Given this list of marker genes Gm22455, Kcnh8, Cripto, Irak3, H2az1, 1110025M09Rik, Lasp1, Zfhx2, Srsf7, Rpl36al, Gm29417, AA386476, Upp1, Epc1, Trim8, Tlnrd1, Polr2a, Gm12536, Rrm2, H2ac15, Rpl27, Gm12100, Gm24451, H2ac21, Mttp, Mllt6, Raly, Rpl3-ps1, Atxn7l3, Cdh1, Rigi, Ccne2, Nynrin, Ndufaf3, Pim3, Snhg9, Mgme1, Hmgcr, Gm12279, Sphk2, Rpl31, Mta2, Cbx3, Mcm7, Snora74a, Kansl1, Pipox, Ing2, Zc3h12a, Tcte2, Tpi1, Hsd17b14, Zic5, Trappc4, Agpat4, Hcfc1, Snora41, Nr0b1, Lrsam1 (leucine rich repeat and sterile alpha motif containing 1), B3galt4 (UDP-Gal:betaGlcNAc beta 1,3-galactosyltransferase, polypeptide 4), Skp1, Gpx4, Mir7079, Nr5a2, Ccnd1, H2ac4, Sumo2, Tnfsf13os, Pfn1, Rrp36, B3gnt2, Myl12b, Snhg20, Snord118, Gm26457, Mir7650, Ddx3x, Cbx7, H3c15, Atp6v1a, Bcl7a (NCBI Gene Id 77045), Gm22579, Hmgn2, Rps10, Rpl22l1, BC005537, Nrf1, Slc7a3, Snord14a, Midn, BC051226, Senp3, Snord45b, H4c18, 4930461G14Rik, Arl15, Mad1l1, Sgo1, Grik3, 6330403L08Rik, Zbtb37, Egr1, Nfyb, Rpl7a, Gm15459, Rpl5, Snord65, H3c14, Hotairm1, Tead1, Ddx6, Zfp36l2, Rpl6, Gm22980, 4933440N22Rik, E230029C05Rik (NCBI Gene Id 671286), Lamtor2, Eif2s2, Phc1, Gm25296, Tfe3, Gm12101, Gm22571, Cox20, Igfbp2, Zwilch, H3c3, Gm26205, Snora17, Rbpms2, Gpbp1, Cbx5, Rpsa, Mir292, Snora24, Hmox1, Chtop, Senp6, Slc7a7, 4833445I07Rik, Jade1, Catsper2, Mir20b, Rps2, Sall1, Mir18b, Rrs1, H4c8, Gse1, Gm13830, Mir6352, Bola1, Itga6, Fbxo38 (F-box protein 38), Tjp2, Trmt10a, Atxn2l, Cdc73, Snord49b, Mir19b-2, Plekha4, Mycn, Gm10138, Moap1, Npm1, Otop1, Etl4, Rpl36a, Tgif1, 1700039I01Rik, Surf1, Ncl, Rbpms, Slmap, Slc25a39, H2ac12, Naa12, Zfp57, Btg2, Gt(ROSA)26Sor, Hdgf, Sox11, Trh, Utp14b, Rab26os, Lefty1, Rpl14, Ep300, Zfp42, Gm15860, Mir290a, Prickle1, Mat2a, Gm25744, Hnrnpa0, 2900009J06Rik, Snora33, Trp53cor1, Ino80dos, Wapl, Rpl12, Aqp3, Herpud1, Mir8120, Jmjd6, Sox2ot, Mir106a, Bahcc1, Mtf2, Lemd2, Wrap53, Pnrc2, Gemin7, Klf2, Kntc1, Bcl3, Scd2, Rpl10a, Tbl1xr1, Gatad2a, Smg5, H3c4, Gm26728, Septin9, 6530411M01Rik, Nop2, Traf7, H1f1, Dpagt1, Nme2, Mir3091, Rpl10, Sall4, 2700078F05Rik, Dnmt3bos, Mgat4b, Mettl23, Gm20652, Rbmxl1, Snhg6, Tfap2c, Mir92-2, Spred1, Xpo1, Arhgef2, Rtraf-ps, Fgf4, H2bc18, H2ac13, Rpl28, Epb41l4aos, Pou5f1 (POU domain, class 5, transcription factor 1), Snora69, Snord104, Cyfip1, Amd1, Glul, Sumo1, Fam169b, Spen, Slc2a3, Hspa8, Eno1, Tefm, Lpar6, Tmem131, Hmga1, Gm24044, Zfp710, Wbp1, Cltc, H4c1 (NCBI Gene Id 326619), Ubb, Dpy30, Gldc, Rcc1, Septin1, H2ac14-ps, Anp32e, Dusp6, D930048N14Rik, Ubqln4, Gm32950, Il17d, Zbtb25, Cggbp1, Gm23187, H2af-ps2, Gm12974, Lrrc8d, Pml, Arid1a, Snhg3, H2bc3, Etv4, Tdh (NCBI Gene Id 58865), 1700016A09Rik, Rps12 (ribosomal protein S12), Gm23201, Mir290b, 2410006H16Rik, Set, Gm24455, Ttc39d, Nop56, Rpl13, Fblim1, Gm22357, Gm12980, Lmln, Rps23, Tcf15, Slc29a1, Znfx1, A230083N12Rik, Zfp219, Snhg8, Ube2k, Fut9, Ahdc1, Zfhx3, Dedd, Fem1b, Mcl1, Usp37, Sox12, Snord68, Trip12, Wsb2, Ubc, Dusp1, Yars2, Srsf2, Chd2, Enah, Ywhaq, Snord59a, Snord1a, Snora62, Zmynd8, H2ac8, Hnrnpc, Actg1 (actin, gamma, cytoplasmic 1), Rundc3a, Snhg12, H4c4, Patz1, Gm22489, C330002G04Rik, Snora26, Zfp704, Rplp0, H4c2, Eef2, Eif5a, Mir6935, Stx3 (syntaxin 3), Rnd3, Snord15a, Mt1, H2ac5-ps, Pten (NCBI Gene Id 70161), Zfp706, Gdf3, Msantd3, Acot13, Setd5, Gm26608, Chaserr, Gm26885, H2ac19, Slc25a36, Cnot8, Snora52, Ipo7, Ndufa13, Dnajb4, Gpa33, Setd1b, Sema6a, Tuba1a, Esrrb, 5730420D15Rik, M6pr, Rps8, Srsf1 (NCBI Gene Id 70724), Mllt10, Nphs1os, Pcgf2, Dapk3, Mir124a-1hg, Atp5f1b, Snord52, Gm10382, Smad7, Rarg (NCBI Gene Id 19411), Birc2, Hspe1, H2bc22, Snora61, Surf2, Snord12, Zbtb8os, Tpt1, Gm25894 (predicted gene, 25894), 1600020E01Rik, Prdx1, Rfc4, Gm23301, Scd1, Med22, Ddit4, Dnaja1, 6330562C20Rik, H4c6 (H4 clustered histone 6), 2610035F20Rik, Sqstm1, Gm25835, 9330151L19Rik (RIKEN cDNA 9330151L19 gene), H1f3, Slc9a2, N4bp3, Zfas1, H3c2 (H3 clustered histone 2), Snora68, E230016M11Rik, Rpl37, Rbmxl2, Sde2, Rps18, Calm1, Actb, Mir1949, Bend3, Gm4419, E2f3, Bcat2, Hnrnpa2b1, H1f4, Gm24016 (NCBI Gene Id 115490074), 0610009L18Rik, Gm12925, Smim14, Pabpc1, Apoe, Epop, Ubtf, Altre, Trp53bp1, Snord83b, Ss18, Tmem253, Gabbr1, Vangl1, Gm31266, Gm26766 (NCBI Gene Id 108168238), Mir291b, Ark2c, Kmt5a, Mat2b (NCBI Gene Id 68881), Rpl9, Etf1, Sgk1, Snord1b, Alg13, Gm26224, Pdk1, H2bc8, Sulf2, Gm9887, Snord82, Ints5, Notum, Gm23130, Mup6, Snora78, Rplp2, Asns, Rps17, Rps15, Snapc5, Hk2, Cd9, H4c9, Gm24086 (NCBI Gene Id 115487627, predicted gene, 24086), H3c11, Tanc1, Snrpn, Id3, Gm26448, H3f3b, Myl6b, H3c6, AI480526, Cdc42se1, Plekhf2, Mir7067, Rcc2, 1700008O03Rik, Cnpy1, Rps5, Acsl3, Ints6, Mir6516, 1700019D03Rik, 4933417C20Rik, Vdac1, Snord110, C130036L24Rik, Gtf3c6, Snord58b, BC031181 (cDNA sequence BC031181), H2bc27, Sema4b, Hnrnpa1, Hmgb2, Serpina3i, Gm22984, Gm25867, Neat1, Hspa5, Ndufa7, Ndufb10, Dst, Snord13, Psmd11, Mir291a, Hsp90aa1, Snora16a, Sfpq, Hnrnpdl, Gapdh, Rpl22, Jmjd1c, Resf1, Slc38a1, Abcg1, Dbf4, Utf1, Snord73b, Tfrc, Mir1894, Rps9, Tet1, Frmd8os, 2810004N23Rik, Nhsl3, Dgkh, Mir292b, Srm (spermidine synthase), Gm11772, Tmpo (thymopoietin), Ccn2, 1700023H06Rik, Nop58, Clhc1, Tsc22d1, H2ac22 (H2A clustered histone 22, NCBI Gene Id 319170), Pdf, 1700096K18Rik, Rps28, Snord4a, Tmem39a, En2, Vps52, H2ax, Rpl18, Mir207, Fam169a, Slc3a2, Zic2, Snord99, Snord60, Zscan10, Tenm4, Insig1, Zc3h10, Epha2, H2bc12, Klf3, Gas5, Rps27a, Gm22711, Gm25855, Mir293, Zbtb8a, Rab34, Pank1, Schip1, Rpl35a, Lyset, Gm11398, Gm23969, Cic, Apol7d, Gm43403, Arrdc3, Nufip2, Mir363, Azin1 (NCBI Gene Id 73525), Rpl18a, Gm25878, Mideas, Mir5136, Suz12, Cd68, Iqcg, Slc2a1, Fxr1, Slc25a12, Tardbp, Msh2, Snora57, D130058E05Rik, Snx5, Mrps18b, Snord45c, Sulf1, Eif4a1, Lbr, 3010003L21Rik, Lmnb1, H2ac20, Malat1, Rbbp4, Gm15441, Rpl23a, Pgk1, Tubb5, Snora73a, Tmem79 (transmembrane protein 79), Mirlet7i, H3c7, Tet2, Rpl13a, Hnrnpf, Eapp, Gm14024, Tbx3, Gid8, Snora64 (NCBI Gene Id 104366), Hsp90ab1, Rpl21, Fzd5, Snora21, 2610037D02Rik, Rnu7 (NCBI Gene Id 19866, U7 small nuclear RNA), Mesd, Hnrnpab, Slbp, Rplp1, Ndufs1, Gm16096, Tbc1d10b, Hoxa1, Acp6, Etnk1, Gm11335, C230096K16Rik, G3bp2, Zfp568, H2bc11, Ptbp1, Rps20, Amotl2, Elovl6, H2bc13, Ntn1, Rest, Mllt11, Snord87, Tbc1d8, Gpi1, Sox2, Birc6 (baculoviral IAP repeat-containing 6), Slc20a1, Tiparp, Mir1907, Dsg2, Pdgfa, Gm15420, Usp31, 5730405O15Rik, Hnrnpa3, B4galt6, Btg1, Dppa5a, Hnrnpll, 1810059C17Rik, H2bc6, Dnmt3b, Trim28, Ptp4a2 (protein tyrosine phosphatase 4a2), Fscn1, Aldoa, Jarid2 (jumonji and AT-rich interaction domain containing 2), Gm20033, Snord43, Trib3, Rpl11, Snora3, Mfsd11, Gm26511, Rabggtb, Mybl2, Cdk9, Rpl39, Rbm47 (NCBI Gene Id 338502), 5430416N02Rik, Gm15222, Mkrn1, Gm23202, Ccnl1, Ubald2, Daxx, Myl12a, Snora73b, Cradd, a, Cdk5rap2, Gm24452, Gm24029, Pdia3, Lncenc1, Txnip, Socs2, Ap4m1, Srsf5, Anp32b, Hells, Ddx39a, Mindy1, Hnrnpu, Tm7sf2, Dnajb14, H4c3, Pou4f2, Ddx5, Mobp, Gm23639 (predicted gene, 23639), Ftl1, Ubl3, Eed, Gm26202, Ppp1r15a, Commd5, Mir17hg, H2ac7, Gm19705, Snord42a, Mylpf, Spmap1, Mir191, Mtcl1, Spink10, Crebzf, H2bc15, Gm19721, Phf23, Gm23344, Gm23455, Znhit2, Eef1g, Tle4, Zfp36l1, Gm4285, Snord2, Zbtb7a, H2bc7, Gm25091, H4c11, Snora44, Lypla1, Gcn1, Prune1, Pbld2, Kis2, Rpl41, Rnu11, Eef1b2, Ino80d, Zfp428, Snhg7os (small nucleolar RNA host gene 7, opposite strand), Snhg5, H4c14 (NCBI Gene Id 97122), Rps26, L1td1, Snord49a, H3c13, Mir1893, H3c1 (H3 clustered histone 1), Tti2, Eif4g2, Grcc10, Shld2, Bcat1, Ctbp2, Eif1, Eif4e2, Rps11, Snord42b, 2810013P06Rik (RIKEN cDNA 2810013P06 gene), Gm10244, Hs6st1 (NCBI Gene Id 50785), Rnf157, Lias, Mir7655, Brd2, Snord17, Mir425, Ctnnd1, Rcor2 (REST corepressor 2), 4931406C07Rik (RIKEN cDNA 4931406C07 gene), Fbxo5, Wasf2, Anp32a, Trim6, Tbx3os1, Eef1a1, Rpl3, Snord38a, Rab13, Mir6236, Spp1, Snora65, Cep95, H2ac11, Gtf2a1, Zfp740, Snurf (SNRPN upstream reading frame), Hnrnph3, Fbxo36, Nfib, Spry2, Gadd45g, H2ac18, Snora43, Rpl7, Lockd, Kat6b, H3c8, 4931440P22Rik, Kat2b, Rps15a, Gm26330 (predicted gene, 26330), Hes1, Dynll1, Itpk1, Teddm2, 2010110E17Rik, Eif4a2, Tcea3, Yjefn3, Pym1, Usp7, Trps1, Rpl26, Gm16136, Sinhcaf, Ccnb1, Ppp1r10, C430039J16Rik, Glud1, Rps27, Serbp1, Rhbdd3, Mir7687, Zfp459, Mir124a-1, 1110038B12Rik, Sox21os1, Gm10250, H2bc21, Fgfr1, Lrrc2, Gm23650, Ssr2, Zfp532, Snord37, Kpnb1, Gm24299, Gm21992, Spindoc, 2310014F06Rik, Gm35986 (predicted gene, 35986), Slc38a2, Tdrd3, Sdc4, Kdm4c, Gbx2, Kdm5b, H3c10, Rad21, Srsf3, here is a description of the gene set: Mouse Gene Set: AFF4_TARGET_GENES Genes containing one or more binding sites for (Aff4) in their promoter regions (TSS -1000,+100 bp) as identified by GTRD version 20.06 ChIP-seq harmonization. studied in species Mus musculus from publication Yevshin I, Sharipov R, Kolmykov S, Kondrakhin Y, Kolpakov F (PMID 30445619)